The following is a description of a gene set: Human Gene Set: WP_GENES_ASSOCIATED_WITH_THE_DEVELOPMENT_OF_RHEUMATOID_ARTHRITIS studied in species Homo sapiens Genes associated with the development of rheumatoid arthritis, and this is the list of marker genes: IL6ST, STAT4, HLA-DRB1, PTPN22 (NCBI Gene Id 5779), BLK, ITGAV, CD40, CCR6, PADI4, SLC22A4, IRF5 (NCBI Gene Id 84729), TRAF1, CTLA4, FCRL3, IL2RA, CD244, PHF19, CIITA